The following is a description of a gene set: Mouse Gene Set: CUI_TREG_CARDIOTROPHIN_1_RESPONSE_DN Genes negatively differentially expressed in cell type: Treg upon treatment with cytokine: CT-1 in mouse lymph nodes in vivo. from publication Cui A, Huang T, Li S, Ma A, Pérez JL, Sander C, Keskin DB, Wu CJ, Fraenkel E, Hacohen N (PMID 38057668) studied in species Mus musculus Cytokines mediate cell-cell communication in the immune system and represent important therapeutic targets. A myriad of studies have highlighted their central role in immune function, yet we lack a global view of the cellular responses of each immune cell type to each cytokine. To address this gap, the authors created the Immune Dictionary, a compendium of single-cell transcriptomic profiles of more than 17 immune cell types in response to each of 86 cytokines (>1,400 cytokine-cell type combinations) in mouse lymph nodes in vivo. A cytokine-centric view of the dictionary revealed that most cytokines induce highly cell-type-specific responses. For example, the inflammatory cytokine interleukin-1β induces distinct gene programmes in almost every cell type. A cell-type-centric view of the dictionary identified more than 66 cytokine-driven cellular polarization states across immune cell types, including previously uncharacterized states such as an interleukin-18-induced polyfunctional natural killer cell state., and this is the list of marker genes: Klf6, Junb, Jun, Dusp1, Hspa1a